Given this list of marker genes SDCBP2, IRX1, LIN7A, RRAGD, TENM2, SFRP4, EPB41L2, TSHZ1, TOP2A, CASR, LAMA2, SYTL2, ELAVL4, DOCK2, AMOTL1, NLRP2, RASSF8, TNFAIP3, KLHL35, WDR26, CPSF6, MAFF, CASC3, CYP4F11, SLC33A1 (NCBI Gene Id 9197), PTPN5, PHACTR2, WWC3, PPP1R3F, OSTM1, POPDC3, LEMD2, ELOVL5, IFNGR1, here is a description of the gene set: Human Gene Set: GYORFFY_MITOXANTRONE_RESISTANCE Up to date clinical tests for predicting cancer chemotherapy response are not available and individual markers have shown little predictive value. We hypothesized that gene expression patterns attributable to chemotherapy-resistant cells can predict response and cancer prognosis. We contrasted the expression profiles of 13 different human tumor cell lines of gastric (EPG85-257), pancreatic (EPP85-181), colon (HT29) and breast (MCF7 and MDA-MB-231) origin and their counterparts resistant to the topoisomerase inhibitors daunorubicin, doxorubicin or mitoxantrone. We interrogated cDNA arrays with 43 000 cDNA clones ( approximately 30 000 unique genes) to study the expression pattern of these cell lines. We divided gene expression profiles into two sets: we compared the expression patterns of the daunorubicin/doxorubicin-resistant cell lines and the mitoxantrone-resistant cell lines independently to the parental cell lines. For identifying predictive genes, the Prediction Analysis for Mircorarrays algorithm was used. The analysis revealed genes best correlated with doxorubicin resistance and genes with mitoxantrone resistance. In an independent classification experiment, we applied our model of resistance for predicting the sensitivity of 44 previously characterized breast cancer samples. The patient group characterized by the gene expression profile similar to those of doxorubicin-sensitive cell lines exhibited longer survival (49.7+/-26.1 months, n=21, P=0.034) than the resistant group (32.9+/-18.7 months, n=23). The application of gene expression signatures derived from doxorubicin-resistant and -sensitive cell lines allowed to predict effectively clinical survival after doxorubicin monotherapy. Our approach demonstrates the significance of in vitro experiments in the development of new strategies for cancer response prediction. species: Homo sapiens Genes associated with resistance to mitoxantrone. from publication Györffy B, Serra V, Jürchott K, Abdul-Ghani R, Garber M, Stein U, Petersen I, Lage H, Dietel M, Schäfer R (PMID 16044152)